The following is a description of a gene set: species: Mus musculus Mouse Gene Set: GOCC_CHROMOCENTER A region in which centric, heterochromatic portions from more than one chromosomes form a compact structure., and this is the list of marker genes: Esco2, Cbx5, Taf7l, Sox30, Cbx3, Mbd5 (NCBI Gene Id 98951), Mbd6 (methyl-CpG binding domain protein 6), Aurkb, Trim66, Cbx1 (NCBI Gene Id 319869), Incenp, Piwil2, Sall1, Cdca8, Scmh1, Fmr1, Tinf2, Oip5